The following is a description of a gene set: Mouse Gene Set: GOCC_CYCLIN_DEPENDENT_PROTEIN_KINASE_HOLOENZYME_COMPLEX studied in species Mus musculus Cyclin-dependent protein kinases (CDKs) are enzyme complexes that contain a kinase catalytic subunit associated with a regulatory cyclin partner., and this is the list of marker genes: Ccni, Ccnc, Ccng2 (NCBI Gene Id 12452), Cdk6, Ccnt1, Cnppd1, Gtf2h1, Ccnd1 (cyclin D1), Brd4, Cdk14, Cdkn1a, Cdkn2d, Pcna, Ccnl2, Ccne1, Cdk2, Ccny, Cdk11b, Cks2 (NCBI Gene Id 66197), Ccnjl, Cdk5, Cks1b, Gtf2f2, Cks1brt, Cdk10, Ccnk, Ccnh, Rb1 (NCBI Gene Id 19645), Ccnb1, Ccnf, Gtf2h5, Ccnd2, Ccna2, Psmc5, Cdk16, Bccip, Ccnl1, Cdk13, Snw1, Ccnd3, Cdk5r1 (NCBI Gene Id 52900), Tex24, Cdk12, Ccna1, Ccnb3, Cdk3, Cdk4, Ccnt2, Cdk8, Gtf2h4, Cdk1 (cyclin dependent kinase 1), Ccnq, Med13, Med12, Ccnb1-ps, Ccno, Ccnb2, Gtf2h3, Ercc2, Cdk9, Ercc3, Gtf2h2, Ccne2, Cdk7, Ccnj, Ccng1, Mnat1